Given this list of marker genes Phldb1, Phldb2, Clasp1, Clasp2, Mark2, Gck, Pkd2, here is a description of the gene set: Mouse Gene Set: GOCC_BASAL_CORTEX The region that lies just beneath the plasma membrane on the basal edge of a cell. species: Mus musculus